Given this list of marker genes HADHA, GJB2, FBN1, SYT1, HOXD10, HADHB, AEBP1, GJB6, here is a description of the gene set: Human Gene Set: HP_EQUINUS_CALCANEUS Equinus calcaneus studied in species Homo sapiens Abnormal plantar flexion of the calcaneus relative to the longitudinal axis of the tibia. This results in the angle between the long axis of the tibia and the long axis of the heel bone (calcaneus) being greater than 90 degrees.